The following is a description of a gene set: species: Mus musculus Mouse Gene Set: GOBP_DETECTION_OF_LIGHT_STIMULUS The series of events in which a light stimulus (in the form of photons) is received and converted into a molecular signal., and this is the list of marker genes: Cacnb4, Gucy2f, Irx6, Fech, Guca1a, Gnb1, Sema5a, Cabp4, Cacna1f, Gja10, Crb1, Cacna2d4 (NCBI Gene Id 613257), Cds2, Pde6c, Pnpla2, Cep250, Asic2, Pde6d, Lrit1 (NCBI Gene Id 239037), Arrb1, Pde6b, Opn4, Rcvrn, Rom1, Rrh, Prph2, Rpe65, Pcp2, Ttr, Opn1mw, Tulp1 (TUB like protein 1), Rgr, Gpr52, Opn5, Gpr88, Rbp4, Pcare, Opn3, Aipl1, Reep6, Slc24a4, Cngb1, Gngt1, Gnat1, Rgs9bp, Rho, Best1, Opn1sw, Gnat2, Grm6, Sema5b, Ccdc66, Guca1b, Atp8a2, Gnat3 (NCBI Gene Id 242851), Grk1